Given this list of marker genes PLK4, ASH1L, AP1G1, PAPSS2, RPL10, HYAL1, COL2A1, IDH1, GNPTAB, TBC1D24, NIN, SLC35B2, ALMS1, ATG7, ATP6V1B2, LONP1, here is a description of the gene set: Lumbar scoliosis Human Gene Set: HP_LUMBAR_SCOLIOSIS species: Homo sapiens